Given this list of marker genes ENC1, IP6K2, PROX2 (NCBI Gene Id 283571), CPN2, TNPO1, RASEF (NCBI Gene Id 158158), C5orf63, DUSP6, ANKRD12, CREB1, UGT3A2, TMEM108, ZMYND8, OPRM1, TAFA1, UBXN8, RMDN2, ODAM, SLC35A3, PTPRD, RUNX1T1, AP3M1, FGF2, EML4, CCDC28B, SKIDA1, ZMAT2, TM9SF3, GOLGA1, ZNF706, FKBP15, SLC25A53, COPG2, GSKIP, HMGA2, CBFA2T3, RNF166, ZNF143, SERPINB4, WFDC6, TRIB2, LRRC15, QRSL1, OPRPN, PLEKHG1, KLHL24, MAP3K7, PTCH2, CDKAL1 (NCBI Gene Id 54901), WDR36, KRTAP1-1, C1QB, LRCH2, SGIP1, PNMA6A, NFS1, KIF5C, WDFY3, NME2, YWHAH, ADAM12, REG3A, RNF169, TRAPPC3, LYST, RPS6KL1, CDKN2AIP, SPINK8, ENTPD5, ADRA1A, ZNF239, COL5A1, CD53, KRTAP2-2, R3HDM1, MOG, MAP3K1, BRPF3, SNX4, NT5C1B-RDH14, C2orf69, NUP54, CCNT2, HK1, CAMK2D, RFX3 (NCBI Gene Id 5991), SEC24C, MTCL2, LECT2, ADGRB1, WEE1, MAMDC2, PCSK5, AOX1, METTL8, PPM1B, SLC39A11, AUTS2, SYPL2, YTHDC1, AMFR, TSHZ2, MMP28, SPMIP6, TRIM71, TGOLN2 (trans-golgi network protein 2), LARP1B, CCNY, SOX6, FBXO11, ID4, SEMA3C, ENAM, TBC1D8B, SPCS1, PM20D1, STK17A, FHIP2A, NMD3, SNAI2, FCHSD2, RAB11A, DSC2, CFI, PIAS3, ALDH6A1, SH3BP5, RLIG1, DNAJC16, ACYP2, SLC5A3, FBXO21, JARID2, TSHZ1, MAPK10, IGF2R, C15orf40, DNAJC9 (NCBI Gene Id 23234), PIK3CG, PNMA3, SIK3, ABCA1, MTF1, ACER2, SEMA3A, DDX60, ANKRD27, ERCC6, FSTL1, MAGED2, GET3, LZIC, FAM9A, DMTF1, NR3C1, GPN3, DDIT4L, PDHA1, NEIL3, APOL6, USF3, HDHD2, UBE2D3, BACE2, BCAT1, here is a description of the gene set: Genes predicted to be targets of miRBase v22 microRNA hsa-miR-4709-3p in miRDB v6.0 with MirTarget v4 prediction scores > 80 (high confidence targets). from publication Chen Y, Wang X (PMID 31504780) studied in species Homo sapiens Human Gene Set: MIR4709_3P